The following is a description of a gene set: Genes having at least one occurrence of the motif NNNNNNNAAATCACWGYNNNNNNN in the regions spanning 4 kb centered on their transcription starting sites. This matches the GFI1 transcription factor binding site V$GFI1_01 (v7.4 TRANSFAC). species: Homo sapiens Human Gene Set: GFI1_01, and this is the list of marker genes: HBP1 (NCBI Gene Id 26959), ELAVL4, PANK1, TCTA, NUFIP2 (NCBI Gene Id 57532), GRK6, EDN1, TCF12, NFIA, CNKSR1, PRIMA1, CACNG3, ELMO3, PTEN, ARHGEF2, PI15, CTDSPL2, GADD45A, PRKAG1, ZFPM2, PHACTR3, BDNF, PDC, H2BC5, GABBR2, FOXP2, KRT26, SPAG7, YIPF4, TCEAL7, EFHC2, MYH10, PCDH8, CGN, BCL9L, H1-4 (NCBI Gene Id 3008), C1QTNF7, ICAM5, MEX3D, LAMA3, EXOC7, SOX15, CDH13, ABCF2, SLC25A18, LMO3, CTLA4, HNRNPA0, PURA, HOXD11, NEXN, CCR7, NGEF, TDRD5, SLCO2A1, KLHL3, HOXA6, MIR22HG, TMCC1, SERTAD4, CDIN1, HOXB8, LCOR, RBM26, DCAF11, XPO5, LUZP1, MRGPRF, LRP2BP, PDE4D, EGFLAM, ZBTB20, TSHZ2, HOXA9, HNF1A, EBF2, H1-6, RHOA, HMGA1, HSD11B1, MAP4K2, SLC4A7, NCAM1, HOXA10, TRIM23, ITGA10, ANP32CP, CD40LG, KLF12, EBF1, CLEC11A, MAP2K7, POU3F1, BNC2, PPARGC1A, HIVEP3, DLG2, IL16, HOXB3, CRYZL1, DPF3, SH3BGRL2, FAM91A1, IRF2BP1, DNAJB4, USP5, ZNF521, BMP4, TRAPPC13, SREBF2, PREP, CACNB2, BTG1, CNTN6, INTS9, PLCD4, TSGA10, RORA, PEA15, TMTC2, RFX7, TGIF1, MEF2C, GRPR, FAM20A, HOXA3, MCTS1, TET2, MIR7-3HG, TCF4, TSPAN7, PHF8, KCNK16, AGPAT4, CDON, PPP2R2A, NKX2-8, MEX3B, TLK1, PHYHIP, MAP2K5, ITSN1, ANGPT1, GAS2, COLQ, MTMR4, PCYT2, PREX2, HOXD10, JPH4, MSR1, BPGM, TMPRSS2, ARFGEF1, GRAMD1C, POLH, HOXA7, JMJD1C, ADGRB3, CLMN, CAND1, MEIS1, SOX4, SKIDA1, RCAN2, ATP5MC2, RTL9, CELF4, JAZF1, GFRA3, SOSTDC1, GPR20, CDH6, PPARGC1B, NR2F2, RPRD2, OTP, ASB4, HOXC8, SLC44A1, AVP, FOXN3, RARB, C2orf15, TFB1M, CSAD, STEAP4, GPR17, ETS1, BRINP3, PDLIM1, CAMK2D, ZIC1, SRSF2, REN, CDX2, VPS50, ZIC3, DDR2, MAP4K3, MAP3K3, CPEB3, ZIC4, STMN1, ANKRD40, WDR81, RAB6B, DSPP, ADD3, MPZL3, SP8, TLR1, KLF15, SOX5, TFEC, NOL4L, PI4K2A, SLC26A3, ICAM4, SOX9, TRDN, GPRC5D, PRDM10, PATL1, TPBG, ALG10, PBX1, SGK2, CHRM1, CREB5, DCX (NCBI Gene Id 1641), PCDHAC2, PTHLH, BRD2, CREM, GABARAP, BCL6, TMEM71, HOXC4, GREM1, MARCHF5, DSG3, PABIR2, TOP1, PROCR, CALN1 (calneuron 1), YWHAE, CLVS1, NRXN3 (NCBI Gene Id 9369), ID2, LINC00670 (long intergenic non-protein coding RNA 670), CCSER2, CLRN1, MYO1C, ATF2, MBNL1, RPS6KB1, TBR1, IRX3, RNF181, BCL9 (NCBI Gene Id 607), TRAF4, HOXB6, MPZL2, SETD3